The following is a description of a gene set: species: Mus musculus Mouse Gene Set: GOMF_DEMETHYLASE_ACTIVITY Catalysis of the removal of a methyl group from a substrate., and this is the list of marker genes: Phf2, Kdm4a (lysine (K)-specific demethylase 4A), Phf8, Kdm4c, Fto, Kdm6b, Cyp3a11, Kdm2a, Mmachc, Jmjd6, Alkbh4, Kdm4d, Cyp3a41b, Kdm3a, Kdm6a, Uty, Kdm5a, Kdm4b, Riox2, Fbxl19, Jarid2, Cyp1a1, Kdm1a, Cyp3a41a, Kdm3b, Riox1, Kdm5c, Kdm5d, Kdm7a, Kdm1b, Alkbh3, Alkbh5, Jmjd1c, Cyp3a44, Alkbh1, Cyp1a2, Rsbn1, Kdm2b, Alkbh2, Hr, Cyp51, Kdm8, Cyp3a16, Kdm5b, Kdm4dl